The following is a description of a gene set: Distance between medial and lateral canthi is more than two standard deviations above the mean for age (objective); or, apparently increased length of the palpebral fissures. Long palpebral fissure Human Gene Set: HP_LONG_PALPEBRAL_FISSURE studied in species Homo sapiens, and this is the list of marker genes: NXN, PIGL, TGFB3 (transforming growth factor beta 3), SPTBN1, GNB2, PIGV, KMT2A, TBL1XR1, AHDC1, DNM1, FZD2, KDM6A, PIGW, RAC1 (NCBI Gene Id 5879), FBXO11, HNRNPK, ARX, CAMK2G, NEUROG1, BMP1, SPEN, AP3B2, PIGO, FTSJ1, EIF4A2, DVL3, POLR1A, CUX1, PIK3R2, INPPL1, GATAD2B (NCBI Gene Id 57459), PDE4D, PIGA, DVL1, PCLO, EIF5A, WNT5A (Wnt family member 5A), IPO8, CCNK, LMNB1, BRAF, PIGY, CRELD1, SPOP, BUB1, ACTG1, DDB1, ROR2, MAP2K2, OTUD6B, WAC, ACTB (actin beta), RNU4ATAC, MAP2K1, DPH5, PRR12, KMT2D, CTCF, TAF4, WARS1, LMBRD2, AFF3, PGAP2, FIBP, KRAS, CLP1, ZFX, ADNP, H4C5, ANKRD11, PURA, PGAP3, HDAC4, RFX7